Given this list of marker genes KRTAP10-8, DYNC2H1, NEFL, MYO18B, PLS3, LMOD1, ADORA2A (adenosine A2a receptor), MARK2, TPM1, RADIL, KRTAP15-1, DMTN, TCHP, ARL6, KATNAL1, ESPN (NCBI Gene Id 83715), LZTS2, CCDC181, APC, KIF1C, GJB6 (NCBI Gene Id 1897), KRTAP4-5, DNAH6, ARHGAP6, TRIM55, KRT6C, DNM2, DYNLT3 (NCBI Gene Id 6990), KRTAP3-2, TWF2, SPECC1, CCDC57, EML5, KRTAP10-10, FAM110C, AURKC, RMDN3, MAPT, ARHGEF2, KIF5A, KIF18B, NARF, CASP1, CFAP52, KRTAP20-2, KRTAP4-9, KRT4, SCYGR2, NEK7, IQGAP1, KIF20B, AURKB, KRT74, MX1, MTUS1, STIM1, MAPRE1, TEK, MT3, KIF1A, RASSF3, KRTAP1-3, REEP4, NICN1, APC2, PACRG, CLASP1, JAKMIP1, DNAL4, LMOD2, MTCL2, TTL, KRT75, APPBP2, INA, HOOK3, ZNF804A, SARM1, PDLIM7, CALM1, RP1, TPGS2, SPACA9, KRTAP9-4, DNAH3, KRTAP5-10, KRT26, SH2B2, TLK2, RASSF5, POTEE, PDLIM1, DYNC1H1, IFFO2, KRTAP19-2, CFAP206, ZW10, FAM161B, TEKT2, VIM, SCYGR1, PDLIM5, ENKD1, CTTN, KATNA1, REEP1, CHMP3, CKAP5, KRTAP2-3, NEFH, RSPH1, KRTAP4-2, CD2AP, NCKAP1, SLC8A3, JUP, KRT71, CLTC, WDR47, ARHGAP18, GFAP, TUBA3C, TUBB2A, TTLL3, DSP, ACTG1, MAP1B, GPER1, KIF3C, KLHL21, KRTAP21-3, DCDC2B (doublecortin domain containing 2B), CLIP3, KRTAP10-5 (keratin associated protein 10-5), SPTBN4, FYN, CFAP45, KIF2C, KRT36, KIF27, TTLL6, CFAP276, KRTAP2-1, ZNF207 (NCBI Gene Id 7756), MYO1B, CSNK1A1, EVPL, DYNC1LI2, TRIM63, SAXO4, KRTAP17-1, SIRT2, CHMP6, CHMP4B, KRTAP25-1, FHDC1, MYO9B, KRTAP4-4, SLAIN1, DNAH10, CRHBP, POTEF, POTEJ, CEP170, EMD, CAMSAP2, GABARAP, CIMAP1D, BFSP2, KPTN, STMN1, TPGS1, COTL1, GRAMD2B, NDRG1, KRTAP3-1, RAB11A, SYNC, DYNC2LI1, EFHC1, WDR90, RMDN1, EML2, GTSE1, ASPM, LMNB1, DIAPH3, KRTAP5-3, KRT72, SPRY2, ARFGEF2 (ADP ribosylation factor guanine nucleotide exchange factor 2), KRT85, KNSTRN, KRTAP10-6, CEP57L1, KRT77, KRTAP4-8, KRT20, KRT73, NDEL1, TCP1, TMEM214, KRTAP8-1, DNAL1, KRTAP13-2, TUBB4A, ODF2, SPAG17, MICAL2, KIFAP3, CCT7, RCC2, NCKAP5L, MYO3A, CEP57, FEZ1, OPA1, NUMA1, MID1, NUSAP1, MAP1S, CSTPP1, CCT4, HAUS7, KRT25, DNAI1, KRT40, SCYGR8, DCTN1, WHAMM, AIF1L, TBCE, KRT84, LRPPRC, HOOK2, TEKTIP1, EML6, MYO6, NCKIPSD (NCBI Gene Id 51517), RIBC2, FMN1, VPS18, SERP1, LDB3, SVIL (NCBI Gene Id 6840), KRTAP10-1, INCENP, SNTB2, ACTB, CFAP144 (NCBI Gene Id 440585), TPM3, MDM1, KRTAP9-2, TUBAL3, TUBA4A, BLOC1S6, SKA1, DNAH7, DNAH5, KIF19, MYO1A, MID2, NCKAP5, KLC4, DNAH2, GABARAPL3, PDLIM2, TRIM54, CALM3, KATNB1, KIF23, MAP1LC3C, TUBE1, INF2, PRPH, KRTAP5-9, CHMP2B, HID1, FKBP4, KRTAP13-3, KIF5B, AKNA, CKAP2, HAUS3, DYNC1I1, CHMP7, KIF22, RACGAP1, PCNT, PKP1, SPMIP9, BICD1, NEFM, KRT27, GABARAPL1, RUSC1, SPMIP8, CDK5RAP3, BAIAP2, HAUS8, DCXR, MTUS2, AVIL, GDPD2, KRTAP4-12, SRC, CHMP1B, MAP9, PIERCE1, CAMSAP1, FBF1, KRTAP4-16, WHRN, SPAG8, KRTAP3-3, ENKUR, MISP, TUBB1, KRT31, CDK1, KIF17, MAPRE3, CHMP2A, LMNA, KRT78, PRC1, KIF24 (NCBI Gene Id 55265), KRT80, SPMIP6, SKA3, KRTAP9-3, KRT18, RHOQ, LRRC49, HOOK1, MAP6, MAP2K2, SNPH, ACTN1, KRTAP4-6, CFAP210, ARHGAP4, EIF3A, CHMP5, CFAP68, CFAP53, TRPV4, KLC2, GAS2L1, TUBA1A, CHMP4A, BCL2L11, DNAH1, KRT7, UPP2, DNAH11, KIF13A, CCDC66, SCYGR7, DYNC1LI1, KRT14, KRTAP10-9, CCT6A (chaperonin containing TCP1 subunit 6A), SPEF1, SYBU, BEX4, KRT83, IQGAP2, TPPP3, INO80, CLIP4, KRT2, TSC1, TEKT3, NEK2, CENPJ, SRPRB, SKA2, KRTAP12-2, KIF20A, KRTAP10-7, KRTAP1-4, ACTBL2, PNN, CCSAP, KRTAP27-1, DUSP22, GAS2L3, KRTAP12-1, FAM83H, KRTAP6-1, KCNAB2, DCDC2C, SCYGR3, RAB3D, DPYSL2, PKP2, DLGAP2, KRT9, FAM161A, TEKT4, LCP1, SHROOM3, KRT82 (NCBI Gene Id 3888), DYNLL2, KRTAP10-11, FBXW11, TOGARAM2, KRTAP5-7, TUBG1, CLDN11, TBCC, SHTN1, TPPP2, TUBA3D, AURKA, NAV3, GOLGA2, KRTAP1-5, KRTAP4-3, DNAI2, KRT39, CHMP1A, KRTAP5-1, CFAP96, TBCA, KLC3, RCSD1, CTSH, KRTAP5-11, CLMP, DYNLT1, TUBB4B, TTLL5, CFAP126, RMDN2, KRTAP11-1, SEPTIN9, CHMP4C, LUZP1, KRTAP5-5, BBLN, COBL, NRP1, TWF1, SHROOM2, DES, MEFV, BFSP1, CDK5 (cyclin dependent kinase 5), DYNLL1, KIF1B, MACF1, TEKT1, RAC1, SPECC1L, KRTAP12-3, HAUS1, CIMIP2C, CDK2AP2, CSNK1D, CEP295, KRTAP9-6, EML1, KRTAP9-7, SCYGR4, ACTN3, MAP1A, PDLIM3, KRTAP24-1, DIAPH1, DCDC1, YES1, CARMIL1, RTN2, ACTL8, KRT37, KIF25, HAUS4, SCYGR5, KRT10, TOGARAM1, KRT3, SLAIN2, DCTN2, TUBGCP5, ATAT1, HCK, KRTAP22-2, DISC1, TUBB3, VMAC, ACKR2, KRTAP26-1, DUSP21, BAG2, KRTAP13-1, KIF3A (NCBI Gene Id 11127), KIF3B, KNTC1, KRTAP5-6, PYCARD, KRTAP5-4, PALLD, FAM110A, MAPRE2, MAP7, KRT28, TBCD, NEK6 (NCBI Gene Id 58167), HAUS2, TUBD1, NUDC, CUL3, GAS8, CHMP4BP1, KIFC1, KRTAP10-4, SLC1A4, CAPN6, SCYGR6, TBCB, MAP7D2, KRTAP4-1, LMNTD2, SPAG5 (NCBI Gene Id 10615), TPX2, HDAC6, POF1B, MAP10, KIF21B, KRT33A, TTLL7, TTLL1, RGS14, KRTAP13-4, SPMIP11, KIF4B (kinesin family member 4B), DNAJA3 (NCBI Gene Id 94389), DDX6, KRTAP21-1, DYNLT2, ACTN2, SAXO2, STAU2, KRT16, DNM3, KRTAP19-5, KIF28P (kinesin family member 28, pseudogene), SHROOM1, CENPE, TUBGCP4, KRT38, KRTAP20-4, KRTAP19-3, LMNTD1, TEKTL1 (NCBI Gene Id 126402), KRTAP21-2, KRT15 (NCBI Gene Id 3866), BCL10, RNF4, CFAP20, KIF16B, KIF13B, EZR (ezrin), KRTAP22-1, CFAP95, CORO1A, PPL, MAP1LC3B, TMEM232, TPM4, SCYGR10, LIMA1, ARL3 (ADP ribosylation factor like GTPase 3), MID1IP1, CDK5RAP2, PSRC1, TUBA3E, KRT87P, NME7, CCT2, MAP3K11 (NCBI Gene Id 4296), KRTAP16-1, SCYGR9, CALM2, CIMAP1A, KRTAP7-1, DNM1, RAC3, TPPP, MAP6D1, CFAP77, CLIP1, KRTAP19-6, ODF1, ABI2, KIFC2, KEAP1, TUBGCP3, KIF4A, SCTR, DLG1, IFFO1, KRTAP19-1, SYNJ1, INVS, KRTAP20-3, CFAP90, KRTAP23-1, EFHB, KIF9, KRT34, IFT70B, PLEC, ANXA1, TPM2, DNM1L, DIAPH2, TUBB8 (tubulin beta 8 class VIII), DCX, CYLD, KRT6A, KIFC3, TTLL4, CORO1B, DNAH12, GAS2L2, KRT24, KRT35 (NCBI Gene Id 3886), FIGN, PDE4DIP, ARPC3, PAK1, KRTAP1-1, TUBB2B, KIF15, KRT12, NES, JAM3, DYNLRB2, EML4, CFAP141, FLACC1, KIF12, PARP4, DYNC1I2, PBXIP1, KRT8, KRTAP29-1, CCT5, HAUS5 (HAUS augmin like complex subunit 5), HSPH1, HAUS6, TTLL11, KLC1, NDE1, TTLL13, SPAG6, TUBG2, TUBA8, KRTAP4-11, KRT222, RP1L1, CSPP1, RIBC1, CNP, MAP1LC3A (microtubule associated protein 1 light chain 3 alpha), KATNAL2, KRTAP9-9, WIPF1, KRT32, TEKT5, PLK1, KRT6B, KIF26B, NIN, FLNA, CIMIP2A, DPYSL3, MX2, DNAH14, MAP1LC3B2, KRTAP19-8, PLS1, RAC2, KRT33B, KIF2A, DNAH9, TUBA4B, KRT5, LDLRAP1, KRTAP19-7, KIF14, RASSF1, EPPK1, DCDC2, KRT13, KIF11, DYNLRB1 (NCBI Gene Id 83658, dynein light chain roadblock-type 1), IFT70A, LMNB2, HNRNPU (NCBI Gene Id 3192), SAXO1, TUBA1B, CFAP107 (cilia and flagella associated protein 107), CLIP2, TPT1, KRT86, AMOT, KIF21A, CFAP161, KRTAP10-12, PIERCE2, AIF1, WAS, EML3, DNAH8, CAMSAP3, KRTAP9-8, AFAP1, KRTAP10-2, KIF26A, FSD1, KIF2B, EFCAB6, ACTA1, HTR2A, KRTAP9-1, KIF6, DPP9, TUBA1C, KRT81, DST, BCAS3, KRTAP10-3, MNS1, MYO9A, KRTAP5-8, KRTAP6-2, EFHC2, KRTAP20-1, SPMIP10, KRTAP19-4, TUBB6, DYRK1A, TUBGCP6, MICAL1, KRTAP12-4, ZWILCH, PRICKLE4 (NCBI Gene Id 54772), SHROOM4, SHANK2, MTA1, MAP4, CASP14 (NCBI Gene Id 8627), NINL, TUBGCP2, SELENOS, MTCL1, KRTAP2-4, MATCAP1, DVL1, KRT76, KRT17, ABRAXAS2, TCP11L1, CEP162, EIF6, GAS2, KRTAP6-3, KRTAP5-2, POTEKP (NCBI Gene Id 90558), KRT79, KRT1, KIF7, MAP2, TUBB8B, SAA1, KRT23, FGF13, POLB, KLHL22, MAP2K1, SPAST, TTLL8, PAFAH1B1, CCT3, PDLIM4, CIMIP2B, TTLL9, CYP2A6, AK1 (NCBI Gene Id 203), TMOD1, ACTC1, PTPN20, KIF5C, DNAH17, KIF18A, CEP170B, SYNM, BOD1, KRT19, REEP2, POTEI, PAWR, MYO5A, REEP3, MYO1C, BIRC5 (baculoviral IAP repeat containing 5), NAV1, TUBB, HLA-DRB1, CLASP2, CCT8, here is a description of the gene set: studied in species Homo sapiens A component of the cytoskeleton consisting of a homo or heteropolymeric fiber constructed from an indeterminate number of protein subunits. Human Gene Set: GOCC_POLYMERIC_CYTOSKELETAL_FIBER